Given this list of marker genes MT-TV, MT-ATP8, NDUFAF4, NDUFA11, CAMKMT, PHKG2, FARS2 (NCBI Gene Id 10667), NDUFAF8, TRMT5, NSUN3, PLPBP, SLC25A3, COA6, COX16, PDHX, NDUFA6, AARS2 (NCBI Gene Id 57505), SLC52A1, COX10, UQCC3 (NCBI Gene Id 790955), TUFM, NDUFB10, PDP1, COQ2, UQCC2, DGUOK, ALDH7A1, MT-TW, MT-CO3, TMEM70, OGDH, EARS2, FH, TSFM, BCKDHA, PDHA1, NUBPL, PHKA2, SCO2, MRPS16 (mitochondrial ribosomal protein S16), PC (pyruvate carboxylase), RRM2B, ATP5F1A, GATC, RMND1, SDHD, PUS1, MT-CO2, PREPL, NDUFAF5, DLAT, COX6B1, MT-TH, TRMT10C, SLC25A4 (solute carrier family 25 member 4), NDUFAF1, PYGL, GFER, IBA57, MT-TS2, C1QBP, TMEM126B, NDUFB11, MTO1, SURF1, NDUFS4, MLYCD, TK2, SLC25A42, MT-CO1, LARS2, MT-TL1, MICOS13, TYMP, ATP5F1E, MRPS7, HSD17B10 (NCBI Gene Id 50828), LRPPRC, DNM1L, PET100, FBXL4, PCCA, AGK, NDUFB7, TAFAZZIN, PHKB, NDUFS1, MT-TT, TKFC, MT-ATP6, PNPLA8, MIPEP, TRNT1, NDUFA8, NDUFS3, MT-ND5, MT-TN, IVD, MT-ND4, MT-TF, COA8, NDUFS6, ACAD9, NDUFS8, TIMMDC1, TPK1, RYR1, MRPS34, NADK2, MT-TK, NDUFS2, FBP1, CYC1, QRSL1, PMPCA, SUCLG1, USP18, SLC25A19, NDUFAF3, SDHA, MT-TE, ETHE1, HLCS, MT-ND3, LYRM4, HADHA, PCK1, NDUFA10, NDUFV1, LIAS, NDUFAF6, LIPT1, SLC25A13, TRMU, COQ9, POLG, BOLA3, LONP1, ATPAF2, ALDOB, LIPT2, SLC3A1, MT-TC, TANGO2, DLD, BCS1L, GTPBP3, COX8A, PPM1B, FOXRED1, LARS1, NDUFB9, ELAC2, MARS1, WARS2, G6PC1, MPC1, VARS2, NDUFAF2, SERAC1, SLC37A4, LYRM7, NDUFB3, COQ8A, PCCB, MRPS22, SFXN4, SUCLA2, MT-CYB, LIG3, SLC25A26, MRPS14, SQOR, ISCU, GATB (glutamyl-tRNA amidotransferase subunit B), PDHB, NDUFS7, COX15, NDUFA1, MT-TQ, NDUFV2, NFU1, CA5A, NAXE, YARS2, ATP5F1D, NDUFA4, MT-ND6, MPV17, MT-ND1, MT-ND2, HADH, UQCRFS1, ATP5MK, FDX2, here is a description of the gene set: species: Homo sapiens An abnormal buildup of lactic acid in the body, leading to acidification of the blood and other bodily fluids. Human Gene Set: HP_LACTIC_ACIDOSIS Lactic acidosis